Given this list of marker genes Bco2, Rbp3, Rho, Plb1 (phospholipase B1), Gpc1, Stra6, Lrp10, Lrp2, Gucy2e, Metap1, Rdh12, Rbp2, Agrn, Sdc3, Gpihbp1, Rbp4, Gngt1, Apoa1, Nmt1, Gpc2, Metap2, Gnb1, Sag, Gpc5 (NCBI Gene Id 239259), Gpc4, Cngb1, Pde6g, Rdh5, Calm3, Apom, Guca1b (guanylate cyclase activator 1B, NCBI Gene Id 224830), Grk4, Gnat1, Rpe65, Sdc2, Opn1sw, Gpc6, Ppef1, Rlbp1, Apob, Apoa4, Dhrs9, Ttr (NCBI Gene Id 98126), Sdc1, Lpl, Cnga1, Sdc4, Apoe, Opn1mw, Abca4, Sdr9c7, Hsd17b6, Fntb, Akr1b10, Camkmt, Calm1, Cyp4v3, Lrp8, Dhrs3 (dehydrogenase/reductase 3, NCBI Gene Id 20148), Gnb5, Awat2, Akr1c20, Nmt2, Akr1c21, Guca1a, Rdh1, Apoc2, Gpc3, Myo7a, Lrp1, Apoc2l, Clps, Apoa2, Rdh11 (retinol dehydrogenase 11), Rgs9bp, Fnta, Bco1, Rgs9, Pde6b, Gucy2f, Rcvrn, Rdh10, Calm2, Rbp1, Akr1c6, Lrat, Grk1, Lrp12, Pnlip, here is a description of the gene set: Mouse Gene Set: REACTOME_VISUAL_PHOTOTRANSDUCTION Visual phototransduction species: Mus musculus